Given this list of marker genes PPTC7 (protein phosphatase targeting COQ7), TMEM167A, ANKRD20A4P, FNDC3B, TMEM144, GABRA6, AGFG1, C9orf72, DHX15, PIP5KL1, DET1, HIC2, GCC2, SGPP1, ANKRD20A2P, CCDC18 (NCBI Gene Id 343099), HOXA1, CREB5, NWD2, COLEC10, PABPN1, MRPS18C, GPATCH8, KCNJ15, ZBTB46, F13A1, BCL2L2-PABPN1, LGALSL, RIMS4, ATG12, FUT1, C6orf120, OSR2, TMEM216, DHX40, GABPB2, IL18R1, GPCPD1, L3MBTL3, ANKRD20A1, ARL8A, KLF6, here is a description of the gene set: Genes predicted to be targets of miRBase v22 microRNA hsa-miR-556-5p in miRDB v6.0 with MirTarget v4 prediction scores > 80 (high confidence targets). studied in species Homo sapiens from publication Chen Y, Wang X (PMID 31504780) Human Gene Set: MIR556_5P